The following is a description of a gene set: Genes predicted to be targets of miRBase v22 microRNA hsa-miR-4521 in miRDB v6.0 with MirTarget v4 prediction scores > 80 (high confidence targets). Human Gene Set: MIR4521 from publication Chen Y, Wang X (PMID 31504780) studied in species Homo sapiens, and this is the list of marker genes: ZEB2, FSD1L, ENO1, CELF6, EDARADD, KCNAB3, TENM1, FBXO28, ZNF609, NETO2, MBNL1, WAPL, LRRC19, DENND1B, ZFYVE1 (NCBI Gene Id 57694), ATXN1, DLGAP5, MSR1, FOXM1, KCTD15, ARG1, ZNRF3, DMRT1, TRABD, RAVER2, LMLN, CNIH4, ZMYM4, ZBTB18, TTC39A, CETN1 (NCBI Gene Id 1068), ACAA2, PGM2, DOCK5, FIZ1, WWOX, HIPK2, COPA, SH2D4B, CDC37L1, NEDD4L, HSPA12A, KIT (NCBI Gene Id 5086), PTBP3, PABPC5, RNF141, TAF5L, KLF6 (KLF transcription factor 6), CPNE4, KLHL42, UGT3A1, EIF2AK3, UBE2C, BCL11A, KLF5, ATG3, GABARAPL2, PPP1R16B, CPSF6, ABR, DMGDH, NCOA2, FAM234B, RRAS2, ZNF22-AS1, VPS13C, MUC3A, AAK1, ATXN1L, CDYL2, CENPF, SRGAP1, PROSER2